Given this list of marker genes Ifitm2, Gadd45b, Ndufv3, Hyi, Mdga1, Mpp2, Add3, Bbc3, Sema6a, Vegfa, Acox2 (acyl-Coenzyme A oxidase 2, branched chain), Klf2, Sesn2, Cul7, Klhl24, Tspan17, Zcchc24, Nfkbia, Cdkn1a, Gpi1, Oaz2, Tacc2, H1f0, Bhlhe40, P2rx3, Gamt, Tnfrsf19, Ptch1, Stc2, Lrrc51, Cacnb3, Cdh22, Pycr1, here is a description of the gene set: Histone deacetylase 7 (HDAC7) is highly expressed in CD4(+)/CD8(+) thymocytes and functions as a signal-dependent repressor of gene transcription during T-cell development. In this study, we expressed HDAC7 mutant proteins in a T-cell line and use DNA microarrays to identify transcriptional targets of HDAC7 in T cells. The changes in gene expression levels were compared to differential gene expression profiles associated with positive and negative thymic selection. This analysis reveals that HDAC7 regulates an extensive set of genes that are differentially expressed during both positive and negative thymic selection. Many of these genes play important functional roles in thymic selection, primarily via modulating the coupling between antigen receptor engagement and downstream signaling events. Consistent with the model that HDAC7 may play an important role in both positive and negative thymic selection, the expression of distinct HDAC7 mutants or the abrogation of HDAC7 expression can either enhance or inhibit the signal-dependent differentiation of a CD4(+)/CD8(+) cell line. Genes down-regulated in DO11.10 cells (hybridoma) by expression of transciptionally activating and by transcriptionally repressive forms of HDAC7. Mouse Gene Set: KASLER_HDAC7_TARGETS_2_DN from publication Kasler HG, Verdin E (PMID 17470548) studied in species Mus musculus